The following is a description of a gene set: Any process that activates or increases the rate or extent of endothelial cell proliferation. Human Gene Set: GOBP_POSITIVE_REGULATION_OF_ENDOTHELIAL_CELL_PROLIFERATION studied in species Homo sapiens, and this is the list of marker genes: MYDGF (NCBI Gene Id 80302), PDCL3 (NCBI Gene Id 82833), MIR503, EGR3, ZNF580, GHSR, VEGFB, MIR146A, VEGFA, ADAM17, GATA2, PROX1, GHRL, HMOX1, EGFL7, SP1, NRARP, BMP6, ITGB3, RPTOR, FGF7, MIR132, SEMA5A, POLD4, JCAD, IGF2, MIR21, MIR101-1, IL10, ITGA4, WNT5A, MIR487B, KDR, PROK1, PDCD6, CAV2 (caveolin 2), STAT5A, MIR27A, RICTOR, NR4A1, AGTR1 (angiotensin II receptor type 1), MIR10B, MIRLET7B, SIRT6, PPP1R16B, FGFR1, FGF2, HSPG2, MDK, CYBA, AKT3, PDGFB, AKT1, SCG2, HTR2B, STAT3, VASH2, MIR499A, HMGB2, FGFBP1, CDH13, ACVRL1, HMGB1, HIF1A, PLXNB3, MIR135B, NF1, MIR130A, MIR126, THBS4, NRP1, FGF10, F3, TEK, LRG1, MIR27B, NRAS, APELA, PLCG1, PDPK1, ARNT, NRP2, PIK3CD, MIR10A, NUS1, ECM1, EGF, CCL26, PRKD1, CCR3, TGFBR1, MIR495, PRKD2, CCL24, PRKCA, APLNR, APLN, EMC10, JUN, BMP4, GDF2, ANG (angiogenin), MIR29A, FLT4, CCL11, AGGF1, SIRT1, MIR23A, TNFSF12, CXCL12